The following is a description of a gene set: species: Homo sapiens The aim of this study was to employ a systems-level analysis to elucidate gene expression networks operating in the CD4 T-cell responses which underpin human atopic disease. from publication Bosco A, McKenna KL, Firth MJ, Sly PD, Holt PG (PMID 19414752) Human Gene Set: GSE14908_RESTING_VS_HDM_STIM_CD4_TCELL_ATOPIC_PATIENT_DN Genes down-regulated in CD4 T cells from atopic patients: resting versus stimulated with allergen (house dust mite)., and this is the list of marker genes: GTPBP6, NUDT6, SLK, ITIH5, ANKS3, BCKDHB, RAB10, IL16, CMTM6, DCTN1, ATN1, GZMA (NCBI Gene Id 3001), LAPTM5, SLC44A1, ACP6, TM7SF2, MLLT10, RDH5, MRPL24, GNPDA2, RMND5A, COL19A1, SPICE1, GEM, CSNK1D, ITCH, EIF5, APBB2, MYL11, PYROXD1, GDI1, UBAC2, WBP2, FTL, ACTN2, IGKC, MSX1, ZYX, SLC52A3, PCDH15, ZFP36L1, FAM120B, CDKN1B, SESN3, PDCD10, FOXO1, TSHZ1, CHURC1, CRIM1, PSEN1, RAMP1, MEF2D, CBLL1 (Cbl proto-oncogene like 1), WLS, UBL5, ARF5, DENND4C, MPZL2, CLCN2, CDKN2C, NAMPT, DNAJC5, OCIAD1, SH3GL1 (NCBI Gene Id 8179), RASGRP1, SFXN3, NAA30, TSPAN13, ACTR1A, MCAM, TMEM234, IGF2R, ARL6IP1, SOX4, VAMP8, C16orf87, DTX3, WDR1, VPS35L, SLC22A5, SLC35F6, TNFRSF18, MBD2, RGCC, NCOR1, METTL23, HINFP, PLCB2, HLTF, NFAM1, ANXA2, GADD45B, VPS9D1, ACVR1B, RPLP1, ANKH, ZNF622, PITPNM2, RICTOR, RAMAC, ARHGAP5, MS4A1, FMO5, SP3, GATAD2B, ARL4A, PRKDC, CSAD (cysteine sulfinic acid decarboxylase), FAM83F, CCDC106, FOSL2, HMBOX1, FOXP1, C5orf24, FGF13, ZNF18, APPBP2, ERRFI1, DUSP16 (NCBI Gene Id 80824), RBM43, SMNDC1, MOV10, TTC14, BCL9, PIGO (NCBI Gene Id 84720), MAP7, YEATS4, MTURN, NCF4, SNAPIN, SLC41A3, FAM91A1, CAPN2, ISG15, TMEM123 (NCBI Gene Id 114908), NGDN, MKNK1, HINT2, MCOLN3, UAP1L1, HPS3, DUSP11, NUP210, CD86, ALDH6A1, GALNT11, CA9, RAB29, OR2S2, FBXO33, EMSY, LGALS7, SP2, QRICH1, TCF20, BRD2, TMLHE, PACSIN1, PRKCH, CGGBP1, STK25 (NCBI Gene Id 10494), PBX1, TAX1BP1, MINDY3, ZBTB11-AS1, TNRC6A, PRDX6, PGS1, DPM1, NT5C3A, FZD7 (NCBI Gene Id 8324), KDM3B, SMC5, EQTN, CHD7, NSUN4 (NCBI Gene Id 387338), ULK2, DDRGK1, MARK2, SRPK1, USP25, SPIN1, TMEM131, CMTR1, INAVA, DOCK8 (dedicator of cytokinesis 8), INPP5K, PRKAB1, GLMP, RIOK1, COQ8A (coenzyme Q8A), PRPF39, TRIO, CEP70, BCL2 (NCBI Gene Id 596), DIAPH1, CRK, SMG6, ZFP36L2 (NCBI Gene Id 96706), UNC50